The following is a description of a gene set: Human Gene Set: GOBP_REGULATION_OF_FATTY_ACID_TRANSPORT species: Homo sapiens Any process that modulates the frequency, rate or extent of fatty acid transport., and this is the list of marker genes: PLA2R1, IRS2, PLA2G4A (NCBI Gene Id 5321), P2RX4, PLA2G10, EDN1, FIS1, IL1B, CYP4F2, SYK, OXT, MIF, FABP3, AKT1, P2RX7, PLA2G3, THBS1, PPARA, ACSL5, EPRS1, TNFSF11, ACSL1, REPIN1, NTSR1, ACSL4, ERFE, AKT2, CYP4A11, PTGES, TNFRSF11A, AVPR1B